The following is a description of a gene set: from publication Amit I, Garber M, Chevrier N, Leite AP, Donner Y, Eisenhaure T, Guttman M, Grenier JK, Li W, Zuk O, Schubert LA, Birditt B, Shay T, Goren A, Zhang X, Smith Z, Deering R, McDonald RC, Cabili M, Bernstein BE, Rinn JL, Meissner A, Root DE, Hacohen N, Regev A (PMID 19729616) mouse primary BMDCs were stimulated with tlr ligands and gene expression changes were profiled on Affymetrix arrays studied in species Homo sapiens Human Gene Set: GSE17721_LPS_VS_CPG_1H_BMDC_DN Genes down-regulated in comparison of dendritic cells (DC) stimulated with LPS (TLR4 agonist) at 1 h versus DC cells stimulated with CpG DNA (TLR9 agonist) at 1 h., and this is the list of marker genes: FBXO21, NUP62, DRD4, BRD2, CD200, TGIF1, CDKN1A, USP47, LIG3, ZNF207, TBC1D8, PPP1R10, SMARCA2, SERPINB9, MIIP, TRAF1, PHLDB1, DDX46, BCKDHA, ANKRD24, GCC1, PNN, EZH2, FBXW11, DNASE2B, CLP1, KDM1A, KCTD10, IL1B, IER5, PRCP, NFKBIZ, TLK2, PLEK, KIF13A, ARFGEF1, SAMSN1, IDO2, ACSS2, BCL2L2, MAP3K8, DUSP2, RSRP1, CPNE1, ADH1C, TXNDC8, PRSS41, RPE65, NCK2, IAPP, APAF1, SF3B1, PLEKHN1, INPP1, ATOH1, WDR6, MAPK10, ATG4D, RFFL, SIRT1 (sirtuin 1), DMTN, CDK5R1, MTMR1, NFE2L2, PRR14, RBM4, DHCR24, IFT81, OC90, CPXM1, TEN1, IL15RA, MECP2, CPNE2, PSTPIP2, TMEM243, WNT10B, SLC15A2, UBTF, DAPP1, CPEB4, MRM1, AKR1A1, CYFIP2, PCBD1, COCH (NCBI Gene Id 23718), MDM2, CHKA, AMPD3, DDIT4, RAB21, FGL1, TTC39C, HYCC1, GPRIN1, SIN3A, BAMBI, SLC38A2, SPAG7, DOK3, SLC25A37, RCSD1, CUL7, FKBPL, SFMBT2, CBX4, CLK1, KCNS1, CUL9, SOS1, RNF19A, SOSTDC1, TOB2, KLK10 (NCBI Gene Id 5655), RGS1, PFKFB3, ABCC5, KALRN, SWAP70, PPP4R2, CDYL, PUS10, SCNN1G, DMRT1, HSPA1B, CXCL3, RIPK4, STAU1, RASA2, EIF4A1, IL1RN (NCBI Gene Id 3557), C1S, SKIL, NDE1, PBX3, KPNA3, UTRN, TOP1, PHF21A, TSC22D1, PRR13, PRPF38B, ATF4 (NCBI Gene Id 468), MYCN, MAPKBP1, APBB3, DSCAML1, CLIC4, SPARC, ADSS2, CCNG2, ZNF436, AGXT, S100PBP, RASAL2, ICAM4, CHIC2 (cysteine rich hydrophobic domain 2), CDC27, SLC41A1, TMEM143, PIM2, PECAM1 (platelet and endothelial cell adhesion molecule 1), IL1R2, ARHGEF3, KLK7, ABCB10, WNT7B, CCR7, NFKBIA, ITGB1, DERL3, BIRC2 (baculoviral IAP repeat containing 2), SERPINB2, KCNN3, MT1E, DLGAP4, LAMC2, S100B, TMEM59, CDC42EP3, BSN (NCBI Gene Id 90068), CLCF1, KIN, HLA-B, EDN1, AEBP2, SAMD8, ZBTB21, SGMS1, IRF8, GSTM5 (NCBI Gene Id 82154), MTMR7 (myotubularin related protein 7), TNF, SMAD7, TSPAN15 (tetraspanin 15), RANBP10, DTNB, GGT5, CACNA1H, SLC41A2